The following is a description of a gene set: Any deviation from the normal concentration of bicarbonate, HCO3, in the circulation. species: Homo sapiens Human Gene Set: HP_ABNORMAL_SERUM_BICARBONATE_CONCENTRATION Abnormal serum bicarbonate concentration, and this is the list of marker genes: SLC4A4, SLC26A3, KCNJ10, WNK1, CPT2